The following is a description of a gene set: studied in species Homo sapiens Dysfunction of the proximal tubule, which is the portion of the duct system of the nephron of the kidney which leads from Bowman's capsule to the loop of Henle. Human Gene Set: HP_PROXIMAL_TUBULOPATHY Proximal tubulopathy, and this is the list of marker genes: PMM2, MT-ND5, NDUFAF2, NDUFS3, NDUFV2, NDUFV1, NDUFB11, NDUFAF3, MT-CO2, NDUFA11, POLRMT, MT-ND6, MT-CO3, NDUFAF1, OCRL, NDUFS6, MT-TW, MT-ND2, ETFDH, MPI, MT-TS2 (mitochondrially encoded tRNA-Ser (AGU/C) 2), ALDOB, NDUFA1, CLCN5, NDUFS8, MT-ND4, MT-TL1, MT-ND1, NDUFA6, TMEM126B, NDUFB3, NDUFAF5 (NCBI Gene Id 79133), MT-TH, MT-TQ, NUBPL, NDUFB9, COG6, RRM2B, MT-TF, NDUFAF8, NDUFS4, FOXRED1, MT-ND3, NDUFAF4, SLC34A1, LRP2, MT-CO1, NDUFS2, TIMMDC1, NDUFS7, CTNS, NDUFB10, MPV17 (NCBI Gene Id 4358), ETFB, ETFA, NDUFS1, HBB